Given this list of marker genes GLO1, SRGN, PRDX2, HDAC3, UBA52, GNAS, SOD1, TNRC18, IFITM1, IFITM2, ARL2, GUK1, SCG5, SAT1, MYL11, PDIA3, ID2, RHBDD2, GNG10 (G protein subunit gamma 10), CXCL3, PIK3C2B, RPS27, MYB, JUNB, ATF3, ANXA1, CDC37, SERTAD1, UQCRB, ADAM9, SNCAIP, ANXA5, SOCS1, CTSA, HSBP1, ITM2B, NDUFA13, S100A10, CYCS, DSG1, H1-2, TUSC3, AKAP13, COX7A2, IGFBP6, SKP1P1, COX6B1, YBX1, LAPTM4A, COX8A, VKORC1, CDH1, SKP1, RSRP1, ITGAE, FKBP1A, WBP1 (NCBI Gene Id 96445), PGK1, NDUFA2, ATRAID, IFITM3, MYOZ2, ATP6V1G1, GADD45B, RSU1, HLCS, LYZ, INHBB, NDUFA1, DKK3, DNM1L, here is a description of the gene set: Ecteinascidin 743 (ET-743; Yondelis, Trabectedin) is a marine anticancer agent that induces long-lasting objective remissions and tumor control in a subset of patients with pretreated/resistant soft-tissue sarcoma. Drug-induced tumor control is achievable in 22% of such patients, but there is no clear indication of the molecular features correlated with clinical sensitivity/resistance to ET-743. Nine low-passage, soft-tissue sarcoma cell lines, explanted from chemo-naive patients with different patterns of sensitivity, have been profiled with a cDNA microarray containing 6,700 cancer-related genes. The molecular signature of these cell lines was analyzed at baseline and at four different times after ET-743 exposure. The association of levels of TP53 mutation and TP73 expression with ET-743 sensitivity and cell cycle kinetics after treatment was also analyzed. Gene expression profile analysis revealed up-regulation of genes and down-regulation of genes in response to ET-743. The ET-743 gene expression signature identified a group of genes related with cell cycle control, stress, and DNA-damage response (JUNB, ATF3, CS-1, SAT, GADD45B, and ID2) that were up-regulated in all the cell lines studied. The transcriptional signature 72 hours after ET-743 administration, associated with ET-743 sensitivity, showed a more efficient induction of genes involved in DNA-damage response and apoptosis, such as RAD17, BRCA1, PAR4, CDKN1A, and P53DINP1, in the sensitive cell line group. The transcriptional signature described here may lead to the identification of ET-743 downstream mediators and transcription regulators and the proposal of strategies by which ET-743-sensitive tumors may be identified. studied in species Homo sapiens Genes up-regulated in at least 8 of 11 sarcoma cell lines by trabectedin. Human Gene Set: MARTINEZ_RESPONSE_TO_TRABECTEDIN_UP from publication Martínez N, Sánchez-Beato M, Carnero A, Moneo V, Tercero JC, Fernández I, Navarrete M, Jimeno J, Piris MA (PMID 15897246)